Given this list of marker genes TUBB4A, TUBB4B, CCT5, CCT2, TCP1, TUBB2A, TUBA4B, TUBB3, TUBB6, CCT7, TUBA8, TUBA1B, TUBB2B, TUBA3E, TUBA3C, CCT6A, TUBA3D, CCT3, CCT4, CCT8, TUBAL3, TUBA4A (NCBI Gene Id 93373), TUBB1, TUBA1C, CCT6B, TUBA1A, here is a description of the gene set: TriC/CCT forms a binary complex with unfolded alpha- or beta-tubulin. The tubulin folding intermediates produced by TriC are unstable. Five additional protein cofactors (cofactor A-E) are required for the generation of properly folded alpha- and beta-tubulin and for the formation of alpha/beta-tubulin heterodimers. studied in species Homo sapiens Reactome Pathway: Formation of tubulin folding intermediates by CCT/TriC part of: Cooperation of Prefoldin and TriC/CCT  in actin and tubulin folding